Given this list of marker genes PRKCG, SUMO1, SENP7, PNKD, BAIAP2, PRKCB, CALM3, SUMO2, PIAS1, GDI1, STXBP1, SYT1, PPT1, ARL6IP5, SENP5, CALM1, CALM2, CALB1, PIAS3, SENP1, HTT, FUS, C9orf72, USP14, FBXO45 (NCBI Gene Id 414772), SH3GL2, LRRK2, UBE2I, here is a description of the gene set: species: Homo sapiens Human Gene Set: GOCC_PRESYNAPTIC_CYTOSOL The region of the cytosol consisting of all cytosol that is part of the presynapse.